Given this list of marker genes FDFT1, HMGCS2, HMGCS1, FDPS, GGPS1, PLPP6, here is a description of the gene set: studied in species Homo sapiens Human Gene Set: GOBP_FARNESYL_DIPHOSPHATE_METABOLIC_PROCESS The chemical reactions and pathways involving farnesyl diphosphate, an intermediate in carotenoid, sesquiterpene, squalene and sterol biosynthesis, as well as a substrate in protein farnesylation.